Given this list of marker genes Arsk, Galns, Arsa, Sulf2, Sts, Arsb, Arsg, Sulf1, here is a description of the gene set: Mouse Gene Set: GOMF_ARYLSULFATASE_ACTIVITY species: Mus musculus Catalysis of the reaction: a phenol sulfate + H2O = a phenol + sulfate.